The following is a description of a gene set: The gene expression program underlying the specification of human cell types is of fundamental interest. The study authors generated human cell atlases of gene expression and chromatin accessibility in fetal tissues. For gene expression, the study authors applied three-level combinatorial indexing to >110 samples representing 15 organs, ultimately profiling ~4 million single cells. The study authors leveraged the literature and other atlases to identify and annotate hundreds of cell types and subtypes, both within and across tissues. Our analyses focused on organ-specific specializations of broadly distributed cell types (such as blood, endothelial, and epithelial), sites of fetal erythropoiesis (which notably included the adrenal gland), and integration with mouse developmental atlases (such as conserved specification of blood cells). These data represent a rich resource for the exploration of in vivo human gene expression in diverse tissues and cell types. Human Gene Set: DESCARTES_FETAL_INTESTINE_ENS_GLIA species: Homo sapiens from publication Cao J, O'Day DR, Pliner HA, Kingsley PD, Deng M, Daza RM, Zager MA, Aldinger KA, Blecher-Gonen R, Zhang F, Spielmann M, Palis J, Doherty D, Steemers FJ, Glass IA, Trapnell C, Shendure J (PMID 33184181) Marker genes curated from the annotated cluster as represented in the Descartes Human Gene Expression During Development database., and this is the list of marker genes: CDH19 (NCBI Gene Id 28513), SOX2-OT, GRIK3, LINC01505, LINC01198 (NCBI Gene Id 101929344), COL22A1, GPR12, ABCA8, ATP1A2, SOX8, BCAN, NCAPGP1, HCRTR1 (hypocretin receptor 1), NKAIN3, ENPP7P2, SERPINA3 (NCBI Gene Id 95022), TRIM9 (NCBI Gene Id 23206), CMTM5, CHST6 (NCBI Gene Id 4166), PRIMA1, SYNPR, COL20A1, FOXD3-AS1, FLRT1, ERBB4, ENSG00000188897, PLP1, SHC4, SLC35F1, RLBP1, LMO1 (LIM domain only 1), ZNF788P (NCBI Gene Id 388507), SNTB1, CSMD2, TTYH1, MIR9-2HG, GINS3, PTPRZ1, SOX10, COL25A1, SOX2, LAMP5, LGI4, GGT8P, NPTX2, HEYL, METRN, FOXD3, EGFLAM, H1-9P, PAQR6, MEGF10, KCNA2 (potassium voltage-gated channel subfamily A member 2), MPZ, TFAP2A, ARTN, RASGEF1C, S100B